The following is a description of a gene set: Mouse Gene Set: MEISSNER_BRAIN_ICP_WITH_H3K4ME3 Genes with intermediate-CpG-density promoters (ICP) bearing histone H3 trimethylation mark at K4 (H3K4me3) in brain. studied in species Mus musculus from publication Meissner A, Mikkelsen TS, Gu H, Wernig M, Hanna J, Sivachenko A, Zhang X, Bernstein BE, Nusbaum C, Jaffe DB, Gnirke A, Jaenisch R, Lander ES (PMID 18600261) DNA methylation is essential for normal development and has been implicated in many pathologies including cancer. Our knowledge about the genome-wide distribution of DNA methylation, how it changes during cellular differentiation and how it relates to histone methylation and other chromatin modifications in mammals remains limited. Here we report the generation and analysis of genome-scale DNA methylation profiles at nucleotide resolution in mammalian cells. Using high-throughput reduced representation bisulphite sequencing and single-molecule-based sequencing, we generated DNA methylation maps covering most CpG islands, and a representative sampling of conserved non-coding elements, transposons and other genomic features, for mouse embryonic stem cells, embryonic-stem-cell-derived and primary neural cells, and eight other primary tissues. Several key findings emerge from the data. First, DNA methylation patterns are better correlated with histone methylation patterns than with the underlying genome sequence context. Second, methylation of CpGs are dynamic epigenetic marks that undergo extensive changes during cellular differentiation, particularly in regulatory regions outside of core promoters. Third, analysis of embryonic-stem-cell-derived and primary cells reveals that 'weak' CpG islands associated with a specific set of developmentally regulated genes undergo aberrant hypermethylation during extended proliferation in vitro, in a pattern reminiscent of that reported in some primary tumours. More generally, the results establish reduced representation bisulphite sequencing as a powerful technology for epigenetic profiling of cell populations relevant to developmental biology, cancer and regenerative medicine., and this is the list of marker genes: Mpi, Gdap1l1, Atp6v1g2, Rab13, Shank2, Nosip, Ccdc160, Rpl19, Zik1, Pak6, Rnf208 (ring finger protein 208), Ggt7, Foxs1, Coro1a, 4833420G17Rik, Triqk, Zfp599, Lsg1, Tbc1d22b, Rbm4, Col6a2, Prpf31, Fv1, Kcnip2, Capn1, Fam3a, Pak5, Rttn, Nckap5, Wdr83os (NCBI Gene Id 414077), Ppp2r3c, Drc3, Stoml1